Given this list of marker genes NR5A1, TOE1, SRY, SOX9, MINPP1, here is a description of the gene set: Abnormal scrotal rugation Anomaly of the folded ridges (wrinkles) of skin of the scrotum. Human Gene Set: HP_ABNORMAL_SCROTAL_RUGATION species: Homo sapiens